The following is a description of a gene set: studied in species Homo sapiens Human Gene Set: GOMF_HISTONE_H3K27_METHYLTRANSFERASE_ACTIVITY Catalysis of the reaction: S-adenosyl-L-methionine + histone H3 L-lysine (position 27) = S-adenosyl-L-homocysteine + histone H3 N6-methyl-L-lysine (position 27). This reaction is the addition of a methyl group to the lysine residue at position 27 of the histone H3 protein., and this is the list of marker genes: NSD3, EZH2, EHMT2, JARID2, EHMT1, EZH1